Given this list of marker genes FNBP1L, CACNB2 (NCBI Gene Id 783), TFDP2, FOXJ2, MAP3K7CL, PPP2CA, RFX4, FBXO33 (F-box protein 33), GRM5, CERS6, BICD1, PLEKHA8, ABHD13, NUFIP2, RAD51B, DEK, TECTB, MPRIP, FCHSD1, SLC25A44, SOCS5, TRAF3, JAG2, PCMTD1, ST7, PROM2, ZNF333, AKTIP, UNC5C, EBF1, RBPMS2, SMAD1 (NCBI Gene Id 4086), RASL10B, NFKBIZ, LRP12, SNX12, ADAM10, TUBB3, RAD51, AP3B1, LATS2, TMTC2, SEC24B, ACVR2A, RNF2, TGFBR1, CHGB, ELOVL6, PPP2R2D, BEX5, LUZP1, CSF2RB, PDE6H, TNFRSF11B, GLUD1, ANKRA2, MRS2, TP53INP1, VCF2, RSPO4, RGS7BP, DNALI1, MKRN1, MAZ, PRKD1, PEAK1, SOX4, RHOA, SSR3, AFAP1L1, VTI1A, HOXC8 (homeobox C8), SLAIN2, FZD7, ATP5MC3, ERBB4, MAGEB6, ZNF426, EPHA2, C11orf24, ZNF202, RAP1A, USP15, RAB11A, ELK1, SLC35F5, MAD2L2, SUSD6, NFYB, LRAT, SEZ6L, C12orf60, AMZ1, FBXL20, CPEB2, MBOAT1, THUMPD2, TRPS1 (transcriptional repressor GATA binding 1), SH3BGRL2, BICD2, C16orf87, ZC2HC1A, CEMIP, here is a description of the gene set: from publication Chen Y, Wang X (PMID 31504780) Genes predicted to be targets of miRBase v22 microRNA hsa-miR-3660 in miRDB v6.0 with MirTarget v4 prediction scores > 80 (high confidence targets). Human Gene Set: MIR3660 studied in species Homo sapiens